Given this list of marker genes CASD1, RHBDD1, TMEM14C, PRR15, PTCD2 (NCBI Gene Id 79810), MBD4, MTX1, ARHGEF7, AP5S1, XPO1, BAD, TMEM51, TOR3A, RTP4, COA5, SDHAF2, SYPL1, DNAJC12, DDX19B, NFIL3, SIRT7, GLTP, CCNI, CTNND1, PTGS1, KLHL7, ABCD1, PHF20, PJA2, FAM210B, GUK1, RBM19, E2F6, UBE2D1, ULK2, JAGN1, SLAIN2, KLHL2, TMEM192, REEP1, TMED7, TEX261, SLC25A11, NSMCE4A, CHMP7, SFT2D1, POF1B, NIPSNAP1, MS4A6A, NDUFAF4, TSC22D4 (TSC22 domain family member 4), RAD23A, HELZ, ZCCHC8, BMAL1, RNF111, ASB8, PAPSS1, GPRASP1, SH3BP5L, ASCC2, SCRIB, HAVCR1, RECK, UBE3A, F5, PPIL4, ABHD4, FKBP15, TMEM184C, DPYD, POM121, RNF13, FCGR2A, SVBP, LMAN2, PAPOLG, NUP93, TRIM59 (NCBI Gene Id 353185), NSMAF, DENND6A, ATE1, HACE1, PPP1R3F, CLK2, FGF13 (fibroblast growth factor 13), RPP14, OMA1, RAD17, WDR33, MGAT2, DMAP1, AFG3L2, DBF4, CBFB, LRRK1 (leucine rich repeat kinase 1), GMFB, ALDH18A1, ATG5, CASP8, MED14, RNF214, INTS7, UGDH, POLR3G, ZNF48, SNAPC3, PRRX1, NSDHL, TMEM120B, ECHDC1, SH2D1B, RHOT1, ZSWIM1, UBAP1, AP1G1, RRN3, SRSF11, NEK9, NUDT3, FAM120B, PUS7, GABRB2, GGNBP2, DRAM1, VPS9D1, PIGQ, SLC25A28 (solute carrier family 25 member 28), SACS, NUP160, BIN3, PANX1, ALDH1L1, ITM2B, RNF14, CHUK, TMED3, TDP2, H2AZ1, PIGH, CISH, CCR1, NOL11, KIF1B, SS18, PLBD1, EVI5, RETREG1, PIAS2, KRCC1, CEACAM21, LRRC20, USP39, GTF2I, MAPK9 (NCBI Gene Id 5601), CRCP, TRIM37, PAQR7, DEAF1, PLS3, PURA, MYO5A, IFI30, TRIM28, CEP20, PYCR3, UBP1, RSPO2, COMMD5, DERL1, ZNF426, CTDP1, GRINA, FN1, TLR4, ACO1, RAP1A, DFFB, TM9SF4, RAB40C, HSD17B7 (hydroxysteroid 17-beta dehydrogenase 7), FCER1G, NLRX1, TMEM176B, DGKZ, THAP11, HTR1F, NF2, CAPN10, GMNN, ARMC12, PCNX3, KBTBD4, C5orf15, COMT, MOCOS, SGK3, POLR3A, DDHD2, TIMM8A, here is a description of the gene set: Genes down-regulated in comparison of dendritic cells (DC) stimulated with CpG DNA (TLR9 agonist) at 2 h versus DC cells stimulated with Gardiquimod (TLR7 agonist) at 2 h. Human Gene Set: GSE17721_CPG_VS_GARDIQUIMOD_2H_BMDC_DN from publication Amit I, Garber M, Chevrier N, Leite AP, Donner Y, Eisenhaure T, Guttman M, Grenier JK, Li W, Zuk O, Schubert LA, Birditt B, Shay T, Goren A, Zhang X, Smith Z, Deering R, McDonald RC, Cabili M, Bernstein BE, Rinn JL, Meissner A, Root DE, Hacohen N, Regev A (PMID 19729616) species: Homo sapiens mouse primary BMDCs were stimulated with tlr ligands and gene expression changes were profiled on Affymetrix arrays